Given this list of marker genes RNF180, PDE1B, AANAT, KYNU, BTBD9, SULT1A4, ATP7A, TPH2, IDO2, SRD5A1, GCDH, NADSYN1, SLC34A1, TDO2, ALDH2, ACMSD, SULT1A3, IL4I1, GRIN2A, HTR1A, IDO1 (NCBI Gene Id 3620), HAAO (NCBI Gene Id 23498), KMO, AFMID, TPH1, ASMT, DDC, here is a description of the gene set: species: Homo sapiens The chemical reactions and pathways involving compounds that contain an indole (2,3-benzopyrrole) skeleton. Human Gene Set: GOBP_INDOLE_CONTAINING_COMPOUND_METABOLIC_PROCESS